The following is a description of a gene set: Any process that modulates the frequency, rate or extent of reactive oxygen species biosynthetic process. species: Homo sapiens Human Gene Set: GOBP_REGULATION_OF_REACTIVE_OXYGEN_SPECIES_BIOSYNTHETIC_PROCESS, and this is the list of marker genes: MPV17L, MIR24-1, GRIN1, PPARA, TRAP1, DUOXA2, PRKN, SOD2, SNCA, ARG2, PIKFYVE, PLCG2, MIR21, ALOX5, CYBA, RHOA, SLC18A2, MIR675 (microRNA 675), ABCD2, NDUFC2, ABCD1, CD36, MIR590, SPHK2 (sphingosine kinase 2), PAGE4, TLR4, ABCB7, ZNF205, LCN2, SLC25A33, CFLAR, INS, ADGRB1 (NCBI Gene Id 575), RAB27A, FOXO3, STAT3, CLCN3, SLC5A3, HVCN1, TLR6, DUOXA1, ADCY10, PARK7, CCN6, FYN, UCP1, FAS, MIR181A2